The following is a description of a gene set: Mouse Gene Set: GREENBAUM_E2A_TARGETS_UP Genes up-regulated in pre-B lymphocytes upon Cre-Lox knockout of E2A. from publication Greenbaum S, Lazorchak AS, Zhuang Y (PMID 15310760) studied in species Mus musculus The transcription factors encoded by the E2A gene have been shown to play essential roles in the initiation and progression of lymphocyte development. However, there is still a lack of comprehensive understanding of E2A downstream genes in B-cell development. We previously developed a gene tagging-based chromatin immunoprecipitation (ChIP) system to directly evaluate E2A target genes in B-cell development. Here, we have improved this ChIP strategy and used it in conjunction with microarray analysis on E2A-deficient pre-B-cell lines to determine E2A target genes in lymphocyte development. Both microarray data and ChIP studies confirmed that E2A directly controls IgH gene expression. The microarray assay also revealed genes that were significantly up-regulated after E2A disruption. ChIP analysis showed that E2A was most likely to be directly involved in repression of some of these target genes such as Nfil3 and FGFR2. An inducible E2A reconstitution system further demonstrated that E2A-mediated repression of Nfil3 and FGFR2 was reversible. Collectively, these findings indicate that E2A is a positive regulator for one set of genes and a negative regulator for another set of genes in developing B lymphocytes., and this is the list of marker genes: Bub1, Cdkn2c, Pfkp, Slc12a2, Nusap1, Anln, Scin, Ccnb2, Mad2l1 (NCBI Gene Id 56150), Klhdc2, Plk4, Car2, Tceal9, Top2a, H2ax, Cip2a, Slc7a5, Aurka, Kif2c, Eif4ebp1, Pgk1, Ect2, Ccnb1, Fgfr2, Ccna2, Ttk, Kif11, Mki67, Kif4, Hs3st1, Eprs1, Racgap1, Ptgs1